The following is a description of a gene set: Analysis of the transcriptional response to SARS-CoV-2 compared with other respiratory viruses, including MERS-CoV, SARS-CoV-1 (SARS), human parainfluenza virus 3 (HPIV3), respiratory syncytial virus (RSV), and IAV. Genes up-regulated in MERS-CoV infection (MRC5 cells, MOI: 3, 24hpi) Human Gene Set: BLANCO_MELO_MERS_COV_INFECTION_MCR5_CELLS_UP from publication Blanco-Melo D, Nilsson-Payant BE, Liu WC, Uhl S, Hoagland D, Møller R, Jordan TX, Oishi K, Panis M, Sachs D, Wang TT, Schwartz RE, Lim JK, Albrecht RA, tenOever BR (PMID 32416070) species: Homo sapiens, and this is the list of marker genes: KCNE4, SLC22A20P, CHRNA5, LDLRAD4, LRRC66, SLC8A2, RAET1K, LAT2, C19orf18, DNHD1, NR1D1, NUAK1, TEC, TENT5A, DHDH, VXN, PARD6G-AS1, CFAP70, RAB17, OIT3, FERMT3, FSTL4, MYLK2, GALNT9-AS1 (NCBI Gene Id 100130238), SNORD48, TRIML2, EVC2, C20orf204, C8G, CELF6, TNFAIP3, ADAM32, GABRE, CACNA1G, KLF5, HSPA1A, LINC00426, TAS1R3, ITGA9, LEAP2, PPP1R15A, ALDH8A1, TENT5B, AOC3, SLC22A1, RASGRF1, ZNF317, TULP2, KLF10, ABCC2, SLC1A3, CLEC18B, ANKRD1 (NCBI Gene Id 27063), PHF24, UBAP1L, SPOCK2, DYRK2, PURA, IL1RL1, SORBS1, PMS2CL, APRG1 (NCBI Gene Id 339883), FBXW10B, SOD2-OT1, RAPSN, SLC22A14, RBFOX3, ANKAR, CSF1R, LAG3, ZNF460, HSPA6, CCDC62, SCN1A (sodium voltage-gated channel alpha subunit 1), SPDYA, HUNK, SLC5A11, ZBTB37, ADGRF3, PPM1H (NCBI Gene Id 57460), GATA3, HSPA1B, MATCAP2, DNAH12, CPN2, ZNF473, CCDC117, NHLH1, ANXA2R-OT1, CTAGE1, MYLK3, BAAT, PGF, SYNE4, KBTBD8, HOXA1, EPPK1, COL21A1, AMH, RPP38-DT, ADM5, DCAF4L1, CFAP53, CCDC121, UCP3 (NCBI Gene Id 7352), OSR2, MAMDC2, FBXL14, NAA16, VWA7, ZC3H12D, GRTP1, ZNF778, ANK3, ENDOU, CSRNP1, PPRC1, AURKAP1 (NCBI Gene Id 6791), GRHL1, KCNJ14, ABTB2, MYO7A, ACVR1C, MYH3, ESAM, GUSBP14, MST1R, NFATC3, HSPA1L, H2BC8, CENATAC, SMG1P2, MFSD2B, PM20D1-AS1 (NCBI Gene Id 284581), PTCH2, GPR35, MED26, PROZ, C1orf162, HSPD1, SPMIP1, LINC02731, DUSP8, OVGP1, RNF144B, SENP3-EIF4A1, KLF15, PTAFR, MYLIP, SERTAD4BP, PHEX, CCDC17, NOCT, NAALAD2, SRGAP3, JUN, NGEF, ZNF620, CASP4LP, IDI2-AS1, CLIC2, FLACC1, HSPA7, SLC6A12, PSMD6-AS2, HAS3, GPR156, ACTRT3, IER5, FOXD4, CPEB3, CDK5R1, TRARG1, SYT16, PRKXP1, SLC25A34, BAG3, SLC25A25, FAM90A1, PNLDC1, ZDHHC11, TMPRSS9, TENT4B, HBEGF, LRIG2, FOS, IQCN, SSUH2, SLC28A3, TG, MUC13, NIM1K, AXDND1, RSPH4A, ABL2, LCN10, UBE2MP1, ZC3H12A, MYO5B, PLD6, ENGASE, SPMIP6, OTUD3, DGCR5 (DiGeorge syndrome critical region gene 5), H1-4, DDN, SH3RF2, TNXB, ITFG2, ZNF462, TINCR, CDC42BPG, DEDD2, CUBN, H3C4, KCNH3, AVIL, NEB, NCF1, STYK1, FBLL1, TUBB1, HIVEP3, PVT1, SLC6A13, C5AR1, CHD5, BHLHE41, AOC2, USP49, PTPN6, GPRASP1, GARIN1B, MMRN2, ENSG00000215022, MUC20, MXD1, GADD45G (NCBI Gene Id 23575), CDC14A, RBM15, ALOXE3, GEMIN8P4, NPPA, SMG1P3, ADORA2A, FKBP4, VHLL, NUTM2D, GARIN1A, ITGB7, PYY2, FAM238C, PTGER4, FHDC1 (FH2 domain containing 1), ZCCHC2, ZNF221, ARTN, ZNF398, TTC39A, CYP26B1, CKMT2, ZBTB20 (NCBI Gene Id 26137), CRYAB, DNAJA4, DUSP1, EPC1, XIRP1, TMC4, TYW1B, CTRL, CFAP43, SLC7A5P2, ITGA2B, COL26A1, H4C5, TRPV3, PYGM, ZFAND2A, NOXRED1, SERPINC1, CCDC154, NFKBIE, SMG1P1, BHLHE40, ZNF121 (zinc finger protein 121), CGAS, MICAL2, ATP2A1, CDKN2AIP, NFKBIA, PDZD2, DNAJB1, ZNF543, UNC13D, GCNA, TIGD3, SUSD4, CGN